Given this list of marker genes TGFBI, RNASE6, VOPP1, PPP2R5E, IDH3A, CAPN15, SYNRG, SLC20A1, RBM38, HBP1, PRPF3, INPP4A, ZFP36, ATP11B, RHOQ, SKIC2, SIDT1, ABCC10, SMC1A, RGS2, IKBKB, BTBD1, PHF11, RRN3P1 (NCBI Gene Id 94431), ALOX5AP, MTMR6, RUBCN, PTGDS, ERGIC2, MED1, RAD23A, WDR44, RBM47, SMC6, NAA15, MCPH1, MYCL, TARDBP, ATP13A1, RABGAP1, TCF4, SLAMF1, ZBTB18 (zinc finger and BTB domain containing 18), ST6GALNAC4, AP5Z1, SLC16A10, POLR2B, INTS6, CDK13 (cyclin dependent kinase 13), TYROBP, PMM2, CD4, KIF3B, NCOA3, CYTIP, SIRT7, TGFBR2, KMO, CYP46A1, GRN, KDM4B, HLA-DRB4, CDC123, SLC12A7, TLR7, TSPAN5, CEBPG, KDM2A, OAS1, UGGT1 (NCBI Gene Id 56886), ZNF12, S100A6, LAMP5, IGFLR1, SERPINF2, SHPK, ACTMAP, MAP2K6, MACO1 (NCBI Gene Id 55219), LIG4, NCOA6, EIF3B, TUBB6, RABL6, TAP1, ST14, LILRB4, SYNGR2, CARS1, TRNAU1AP (tRNA selenocysteine 1 associated protein 1), PARP12 (NCBI Gene Id 64761), GZMB (granzyme B), EIF3A, PIK3R1, GPM6B, JCHAIN, OFD1, LAS1L, HCP5, TARS1, CXCR3, GNA11, FLNB, IFI44L, AMDHD2, ECHDC1, PRKCD, MRPS31, FCER1G, DNASE1L3, ELOVL4, WAC, NOP56, EIF5, SMPD3, PRPF40A, STK38, CCR2, CSF2RB, TACC1, TAX1BP1, SPIB, PTPRC, SERPINF1, PUM3 (NCBI Gene Id 9933), TNFRSF21, SRF, P2RY14 (NCBI Gene Id 9934), ATG12, MTDH, SNHG17, TRIM8, CD180, MBD4, TNPO1, KRR1, USP36, OSBPL2, USE1, IL6ST, ST3GAL5, IL3RA, CLIC3, POLB, PLAAT3, SRRT, IGFBP2, HSPA14, SNAPC5, THOC2 (THO complex subunit 2), DBT, TGOLN2, PBRM1, SEL1L3, TRADD, PBX3 (PBX homeobox 3), INPP5F, MAPK1IP1L, DCP1A, MINK1, PRKAA1, RAB3GAP2, JUNB, MS4A6A, THUMPD1, CIAO1, UBN1, KCNA5, SETX, CDH1, KDM5A, MVP, ATP1B3, KRAS, THEMIS2, ISG20, NT5C, SUZ12P1, CISD1, TRAF4, ATP8B1, HNRNPH3, LILRA4, UGCG, GAS6, RNASET2, GPR183, CCDC88A, NOL8, TPM2, ENPP2, DOCK10, TCL1A, CD38, HERPUD1, NXF1, HAUS2, C1D, UNC50 (NCBI Gene Id 25972), PDSS1, here is a description of the gene set: Human CD14 positive monocytes were purified from healthy volunteers’ blood and cultured in vitro for 4, 12, 24, 72 hours. While culturing, macrophages were activated alternatively with interleukin-4 (IL-4 100 ng/ml) or classically with interferon-gamma (IFNg 100 ng/ml)+tumor necrosis factor (TNF 50 ng/ml) or left without activation. Simultaneously, macrophages were also treated with vehicle (DMSO:ethanol) or 1mM synthetic PPARg agonist, Rosiglitazone. We used Affymetrix microarrays (U133Plus 2.0) to analyze activation and PPARg-induced gene expression changes. species: Homo sapiens Human Gene Set: GSE16385_ROSIGLITAZONE_IL4_VS_IL4_ALONE_STIM_MACROPHAGE_12H_UP from publication Szanto A, Balint BL, Nagy ZS, Barta E, Dezso B, Pap A, Szeles L, Poliska S, Oros M, Evans RM, Barak Y, Schwabe J, Nagy L (PMID 21093321) Genes up-regulated in macrophages (12h): rosiglitazone and IL4 versus IL4.